The following is a description of a gene set: Human Gene Set: WP_LIPID_METABOLISM_PATHWAY studied in species Homo sapiens Lipid metabolism pathway, and this is the list of marker genes: PRKACB, PDHA1, PRKAR1B, PRKAG3, AKT3, LIPE, PNPLA2, ACLY, AKT2, PRKAB2, PRKAB1, PRKACA, HILPDA, PRKACG, ACSS2, FASN, ABHD5, PRKAA2, PRKAG2, ACSBG1, PLIN1, PRKAA1, PRKAG1, PRKAR2B, ACACA, BCKDHA, AKT1, PRKAR2A, PRKAR1A